The following is a description of a gene set: Reactome Pathway: Defective SLC29A3 causes histiocytosis-lymphadenopathy plus syndrome (HLAS) The human gene SLC29A3 encodes the equilibrative nucleoside transporter 3 (ENT3). It is abundant in many tissues, especially the placenta and is localized intracellularly on the lysosomal membrane. SLC29A3 mediates the reversible transport of nucleosides as well as anticancer and antiviral agents such as cladribine, cordycepin, tubercidin and AZT. Defects in SLC29A3 can cause histiocytosis-lymphadenopathy plus syndrome (HLAS; MIM:602782), an autosomal recessive disorder characterised by combined features from 2 or more of four histiocytic disorders. species: Homo sapiens part of: SLC transporter disorders, and this is the list of marker genes: SLC29A3